The following is a description of a gene set: Genes down-regulated in comparison of IgD+ peripheral blood B cells versus dark zone germincal center B cells. B cells from human tonsil and blood were sorted using flow cytometry. The human samples were processed immediately ex-vivo using markers for known B cell subsets. from publication Longo NS, Lugar PL, Yavuz S, Zhang W, Krijger PH, Russ DE, Jima DD, Dave SS, Grammer AC, Lipsky PE (PMID 19023113) Human Gene Set: GSE12845_IGD_POS_BLOOD_VS_DARKZONE_GC_TONSIL_BCELL_DN species: Homo sapiens, and this is the list of marker genes: POLE2, UBE2S, MAP3K7CL, NCBP1, RFC2, BCL6, RRAS2, BACH2, CEP43, REEP5, RCOR3, NUDT21, FAF2, MYO9A, CD86, PMF1, KCTD5, USP10, GOT1, NOP2 (NCBI Gene Id 4839), MRPL35, USP34, TRIP13, PTTG3P, GTDC1, POLR3K, GDPD5, FUBP1, RAD54B, HIRIP3 (HIRA interacting protein 3), PDK3, SPEN, CNIH1, VGLL4, MFHAS1, LDHA (lactate dehydrogenase A), DENND4A, COMMD4, TACO1, CD53, CKS1B, GEMIN2, HNRNPD, LNPEP, CDK19, NDUFAF7 (NADH:ubiquinone oxidoreductase complex assembly factor 7), RUVBL1, UBA1, SEPTIN2, MICU2, PRDX1, LYRM4, MDH1 (malate dehydrogenase 1), AIFM1, SKA1, ZWILCH (zwilch kinetochore protein), UMPS, ALOX5AP, ALDOA, WDR41, DCTN4, STAT5B, NOL9, SUPT5H, PPP1R14B, ITPKB, EHD4, ZNF85, KHDC4, PSMB5, PNN, HNRNPC, RABGAP1, ARPC2, ALAS1, DNAJC10 (NCBI Gene Id 54431), SNU13, CHTOP, ERAL1, LAGE3, CR2 (NCBI Gene Id 1380), FAM120A, DTYMK, SNX5, EDEM3, BAZ2B, GPN2, QRICH1, STAU1, RSF1, MYO1E, SNRNP200, SNAPC1, RBBP4, PTMA, PALS1, RAD17, PKMYT1, ZNF410, MCM7, PRCC, TRIM28, AGGF1, SH2B3, MTMR14, SIAH2, TFB1M, HMGN3, IDH2, HERC4, CLCN3, CFAP298, PPA1, BLMH, TSG101, SGMS1, FAM50B, NUP42, CTPS1, PRKCA, PMS2P2, F8, SPTAN1, MTERF3, URM1, NAXD, IRF8, ENO1 (NCBI Gene Id 81977), MARCHF5, OBI1, IMPDH2, ST14, RPRD1A, YIPF1, DNA2, GTF2E2, E2F5, PPIA, NEDD9, SERF2, MYL6B, SUV39H1, AACS, DCPS, CTSH, MRPL58, AP1G1, ZNF117, ELOC, FADS3, GRHPR, MCM2, POP7, CASP3, YIPF5, BAZ1B (NCBI Gene Id 9031), CCT5, DDX56, SWAP70 (NCBI Gene Id 23075), COX8A, EIF2B2, LCP1, TEX10 (NCBI Gene Id 54881), AIM2 (NCBI Gene Id 9447), JPT2 (NCBI Gene Id 90861), AGPS, PGAM1, NAA16, CAPRIN1, DCTN5, GPSM2, SRSF1, NCALD, RSRC2, RBM28, PLA2G12A, DCTPP1, ISOC2, MKI67, PISD, ABCA11P, CLIP2, OSBPL2, UBR5, SRPRA, CSE1L, SAE1, TOP1, MED20, ASXL1, PRKCD, RSRP1, KANK2, PLIN3 (NCBI Gene Id 10226), NAPG, NKIRAS2, TUT7, PUS7, RNF8